Given this list of marker genes Tmem242, Nup107, Qtrt2, Atpsckmt (NCBI Gene Id 68073), Mrpl51, Slc25a39, Spg7, Zmpste24, Tmem120b, Mdh2, Tex2, Ndufb3, Eif5a, Cox18, Nipsnap1, Scrn1, Sec13, Mrps12, Sigmar1, Ndufb2, Lpin1, Mrps6, Thap7, P2rx6, Timm17a, Ndufs6b, Creb3l4, Mrps35, Parp16, Adap2, Etfdh, Mtg1 (NCBI Gene Id 212508), Vps4a, Gatm (NCBI Gene Id 98899), Coq6, Mrpl4, Mrpl15, Pmpca, Mtx2, Zfp354c, Bnip1, Arl2, Mrpl2, Mrps11, Tmem14a, Slc8b1, Cyp1a1, Foxo3, Tmem109, Lmna, Slc22a3, Cept1, Ipo9 (NCBI Gene Id 98447), Aurkaip1, Rae1, Mindy3, Chmp1a, Znfx1, Ntrk3, Fam169a, Slc25a11, Nup93 (NCBI Gene Id 71805), Tomm70a, Atp5f1d, Calm1, Nudt9, Mlx, Slc25a51, Calr3, Ptcd3, Kcnk9, Tmx2, Ndufb6, Sco2, Osbpl3, Bax, Atp5mg, Tmem223, Uqcrc1, Ints1, Rsad2, Rnf5, Gmcl1, Acat1, Rab5if, Coq10b, Dnajb14, Pgrmc2, Uqcrb, Arl6ip6 (NCBI Gene Id 80483), Rab32, Bak1, Rbm15b, Slc41a3, Syne2, Armcx1, Slc29a3, Slc44a2, Ugt2b38, Qrich2, mt-Co3, Rb1cc1, Suox (sulfite oxidase), Bcl2l1, 2210016L21Rik, Spart, Bad, Ndufv3, Fahd1, Alox5ap (NCBI Gene Id 11690), Dap3, Ckmt1, Ccnd2, Nup88, Gstk1, Cep128, Traf3ip3, Nup58, Slc25a42, Tyro3, Slc25a37, Ptgs2 (prostaglandin-endoperoxide synthase 2), Cidea, Slc25a26, Noc4l, Trim27, Trap1, Alox5, Ndufa13, Ran, Mtarc2, Cyp27b1, Pcm1, Gabbr1, Grk2, Pdss1, Mrpl27, Idh2, Misfa, Atp5mc1 (NCBI Gene Id 11951), Efhd1, Snca, Chchd3, Pemt, Syne1, Ghdc, Cask, Higd2a, Slc25a1, Oit3 (NCBI Gene Id 18302), Cox7a2, Atr, Syne4, Bcl2a1a, Haao, Mt3, Agtr1a, Cyp11b2, Foxred1 (FAD-dependent oxidoreductase domain containing 1), Sdhc, Coq5, Rcc1l, Mrps18c, Nup50, Parp8, Mavs, Gpx4, Cyb5r3, Rbmx2, Cps1, Hsd3b8, Spast, Ndufa12, Ptger3, Slc29a2, Cacybp, Smad3, Mcu, Slc25a21, Cyp2b10, Nrp1, Bcl2a1c, Tomm34, Mrpl44, Slc25a24, Dhrs1, Chchd4, Dnase1, Inpp4a, Mcub, Slc44a1, Slc25a33, Bdh1, Ndufa9 (NADH:ubiquinone oxidoreductase subunit A9), Chmp4b, Sdhaf3, Atp5pd, Nrgn, Nav3, Crat, Pebp1, Sorl1, Smim20, Nme6, Narf, S2bpcox16, Coq3, Nup50l, Bckdhb, Apool, Ppp1r15a, Nlrp6 (NLR family, pyrin domain containing 6), Mapk8ip1, Tnmd, Hadha, Mapk3, Gcdh, Ndufb9, Ggn, Maoa, Mrps34, Calr, Acsl3, Pam16 (NCBI Gene Id 66449), Vdac3, Nup42, Tmco1, Mrpl38, Mtmr6, Qtrt1, Fndc1, Apc, Dpy19l2, Dnajb12, Agpat5, Cox8c, Kpna2rt, Rars2, Prnp, Romo1, Mrps14, Cpt1a, Dync1h1, Slc25a27, Nme2 (NCBI Gene Id 18103), Mx1, P2rx7, Mgarp, Habp4, Tmem97, Nrxn1, Lmnb1, Lrrk2, Plpp7, Osbpl7, Hadhb, Ddx19b, Dnajc1, Cox6b1, Lemd3 (LEM domain containing 3), Slc25a3, Slc30a2, Apoo, Ppp1cc, Hsd11b1, Sord, Acacb, Ubb, Coq2, Mrps33, Gadd45gip1, Mrpl33, Eno1b, Ranbp1, Ryr2, Cox14, Miga1, Ndufb4, Nsmf, Parp6 (poly (ADP-ribose) polymerase family, member 6), Bbc3, Atp5mf, Fam162a, Slc25a40, Atad3a, Clip1, Cox16, Cox7a1, Stoml2, Tmem70, Cox11, Sun5, Cnp, Hpn, Xpo1, Rab40b, Plaat1, Stard13, Ptpmt1, Mff, Grpel1, Oma1, Pml, Des, Exd2, Slc22a4, Zc3hc1, Rangap1, Ednrb, Muc20, Tamalin, Nxf2, Mrpl53, Repin1 (replication initiator 1), Ptger4, Slc39a9, Hsd3b1, Tk2, Micos10, Mrpl9, Apeh, 4930550C14Rik, Ern1, Gsdma3, Mrps28, Ubc, Tor3a, Slc25a45, Pum2, Hkdc1, Plcd1, Itgb4, Erbin, Map1lc3b, Trpc7, Mrpl22, Afg3l2, Calm3, Ogt, Ifi27l2a, Slc8a3, Slc25a5, Itprip, Msto1, Bnip3l-ps, Rrm1, Adra1b (NCBI Gene Id 11548), Slc27a3, Bnip3l, Abcd3, Fzd9, Mgst3, Micu1, Mtx3, Rgs7, Spata46, Scai, Dao, Cptp, Prickle2, Tst, Sfxn1, Ltc4s, Lmo7, Lyrm7, Mrs2, Atp5f1c (ATP synthase F1 subunit gamma), mt-Nd4, Mrpl36, Sun3, Ndufa11, Pom121l2, Ldhd, Agk, Cenpv, Stx17, Hax1, Tnpo3, Ptrh2, Cyb5b, Smim30, Abcd1, Pptc7, Flvcr1, Ugt2b5, Nup155, Acad9, Srgap2 (SLIT-ROBO Rho GTPase activating protein 2, NCBI Gene Id 98351), Cmtm3, Ckmt2 (NCBI Gene Id 76722, creatine kinase, mitochondrial 2), Slc25a25, Tmem209, Nup210l, Got2, Myoc, Tmem33, Acads, Itpr3, Mrpl46 (mitochondrial ribosomal protein L46), Pigbos1, Ttc12, Rab7, Vdac2, Vrk2, Nutf2-ps1, Parp1, Dync2i2, Kpnb1, Timm8b, Uqcrq, Mns1, Nup43, Tomm20, Marchf5, Nat8f1, Nup62, Tmem256, Stx1a, Acsl5, Ndufa8, Ndufa1, Sphk2, Nutf2, Cfl1, Miga2, Gsdmd, Micu2, Anxa11, Dhrs2 (NCBI Gene Id 71412), Cabs1, Rtn4ip1, Phf11, Pnpla8, Tmem126b, Vdac1, Pet100, Tspo2, Endog, Smpd5, Cox17, Mrps15 (mitochondrial ribosomal protein S15), Mrpl21, Clpb, Dnajc15, Becn1, Ndufa10, Tomm22, Nup62cl, Eny2, Ahctf1, Sdcbp, Spire1, Lypla1, Timm21, Gle1, Yme1l1, Fam209, Aldh3a2, Mix23, Nucb2, Cox7a2l, Ccdc51, Ociad2, Golt1a, Xpot, Chmp4c, Bcl2l10, Mrps22, Cox20, Gfer, Tubb5, Micos13, Mrpl55 (mitochondrial ribosomal protein L55), Bltp1, Acsl4, Tufm, Wdr3, Sort1, Cybb, Letm2, Nnt, Ggnbp1, Brip1 (NCBI Gene Id 73108), Cox8a, Nlrp10, Acadm, Eno1, Armcx2, Shmt2, Iigp1, Wtap, Phf11b, Mpc2, Tor2a, Mrpl19, Mrps17, Lmnb2, Sco1, Cycs, Mrpl35, Pcx, Cse1l, Mul1, Mrps26, Slc25a19, Cstad, Gtpbp4, Aaas, Armc12, Fis1, Ndufab1-ps, Fgr, Rnf185 (ring finger protein 185), Fam3b, Slc25a38, Ghrhr (NCBI Gene Id 14602), Mrps21, Nudt1 (nudix hydrolase 1), Tmem160, Sirt5, Atp5pb, AU015836, Card19, Apoe, Otulinl, Atp1b4, Rbm15, Pla2g4b, Acaa2, Mta1, Slc25a43, Ctnnb1, Vcf2, Chmp2b, Coq7, Ackr2, Ifi27l2b (interferon, alpha-inducible protein 27 like 2B), Noa1, Tamm41, Mfsd10, Tmem126a, Smad1, Rnf6, Snn, Cyp11b1, Fkbp10 (FK506 binding protein 10), Mtor, Prelid1, Dctn1, Ndufa6, Banf1, Prodh2, Zftraf1, Smpd4, Ndufs4, Nos1ap, Sun2, Atpaf1, Nat8l, Nup54, Prelid3b (NCBI Gene Id 98755), Tigar, Slc25a20, Atraid, Ndufc1, Rdh13, Rmdn3, Degs1, Uqcrc2 (NCBI Gene Id 67003), Prr14, Ugt2b1 (UDP glucuronosyltransferase 2 family, polypeptide B1), Mfn1, Slc25a47, Fkbp8, Terb2, Cox4i2, mt-Nd3, Pla2g4a, Pnpt1, Clmn, Ndufa4, Ndufaf3, Bnip3, Aen, Acsl1, Cyc1, Ednra, Guf1, mt-Cytb, Smdt1, Nup188, Coq4, Rnf123, Htra2, Ipo8, Prkn, Ndufc2, Coq9, Syne3, Plaat3, Cox19, Slc25a16, Ndufv2, mt-Co2, Mrps5, Sdhd, Herc2, Gja1, Timm23, Cenpf, Nat8f7, Phf11d, Il15ra, Abcb8, Grk5, Cnr1, Clpx, Phf8, Ngfr, Sfxn4, Ogdh (NCBI Gene Id 75674), Mrpl49, Lgals3, Mrpl18, Abhd6, mt-Nd6, Slc25a35, Ist1, Bri3bp, Clca2, Star, Slc1a3, Irag2, Gabrb1 (NCBI Gene Id 320243), Atp5mj, Clu, Timm22, mt-Nd2, Cibar1, Surf4, Mrpl47, Ugt2b37, Tmem14c, Pom121, Vapa, Slc25a13, Crls1, Rab11fip5, Antkmt, Dnajc30, Ndufs3, Plekhn1, Ndufb8, Uqcr11, Dhx37, Spag4, Gpam, Hmgcl, Hsd3b4, Mrpl23, Sumo1, Kash5, Mtch2, Prodh, Vps13a, Tomm5, E2f5, Chchd2, Lmntd1, Klk6, Sdhb, Nup214, Alas1, Ndufab1, Pola1, Cebpzos, Abca12, Ugt1a6a, Spata18, Cyp2e1, Chmp5, Mtnap1, Ranbp17, Pmpcb, Mrpl16, Hlcs, Maip1, Nup153, Tmc8, Cyp11a1, Rhot1, Nelfb, Ndufaf6, Atp5me, Prkca, Mrpl58, Mrps10, Ei24, Ipo11, Uqcc3, Ndufb5, Armcx6, Uaca, Stat3, Aifm2 (NCBI Gene Id 78860), Klhdc2, Arg1, Trak1, Plrg1 (NCBI Gene Id 99527), Coa4, Epha3, Nme3, Hacd3, Eci1 (enoyl-Coenzyme A delta isomerase 1), Coq8a, Pink1, Akr7a5, Adra1a, Dele1, Ass1, Ppox, Ucp1, Cyct, Mad2l1, Ube2i (NCBI Gene Id 76085), Glud1, Atp5f1a, Tmpo, Pafah1b1, Smcp, Gk2, Parp11, Myct1, Kcnj11, Ldhb, Mrpl42, Mpc1, Tor4a, Slc25a44, Gcat, Timm8a1, Cep131, Mrgprf, Dnajb2, Plec, Cox7c, Mcm3ap, Htatip2, Rrp12, Mrps7 (mitchondrial ribosomal protein S7), Akap1, Insr, Tmem186, mt-Atp8, Abca8b, Mx2, Chil3, Mtfr1l, Mtch1, Slc25a22, Rps3, Mrps27, Slc25a15, Rap1gap2, Phf20, Ndel1, Cnep1r1, Nme1, Akirin1, Acsl6, Ndufa5, Rnf13, Tmem18, Tpr, Egfr, Slc25a14, Xpo4, Pdk4, Ppif, Akap6, Letmd1, Uqcc2, Myof, Slc25a12, Acad11, Tfdp2, Stmp1, Polr2m, Tspo, Pla2g2a, Yeats4, Ptpn1, Sh3bgrl2, Sephs1, Bcl2a1b, Slc25a32, Cox6b2, Mpv17, Atpaf2, Nemp2, mt-Nd5, Rnf144b, Bin1, Slc11a2, Prkcz, Bcs1l, Mcur1, Ebp, Dst, Dctn5 (dynactin 5), Kif28, Samm50, Rasa1, Canx, Wasf1, Chchd6, Slc25a29, Cmc4, Nxf1, Phf11a (NCBI Gene Id 71191), Ttc19, Mrpl3, Cox7b2 (NCBI Gene Id 78174), Cdk2, Chchd2-ps, Agpat4, Gch1, Polg, Ivd, Tmem38a, Fundc1 (NCBI Gene Id 72018), Nrm, Alas2, Gapdhrt, Gramd4, Lmntd2, Tent4a, Abcg2, Uqcrh-ps1, Dusp18, Mrpl34, Immp1l, Mtfp1, Ndufs6, Mrpl57, Sfxn5, Chmp6, Cbx3, Slc25a28, Majin, Slc25a30, Aifm1, Sirt4 (NCBI Gene Id 75387), Mrps18a (mitochondrial ribosomal protein S18A), Suv39h1, Mthfd2l, Cisd1, Cpne1, Mief1, Smim26, Mrpl52, Abcb7, Gata6, Cetn3 (centrin 3), Mrpl39, Cox7b, Tmem43, Spata19, Dhfr, Slc25a34, Dhodh, Mrpl20 (NCBI Gene Id 73950), Bik (NCBI Gene Id 12124), Tnks, Mad1l1 (NCBI Gene Id 17120), Timm13, Tomm7, Selenon (selenoprotein N), Cyp2u1, Nlrx1, Rif1, Phb2, Hsd17b8, Grpel2, Tmc6, Myo6, Akt1, Ngrn, Dnm1l (NCBI Gene Id 74006), Fxr1, Rhbdd1, Nr4a1, Terb1, Abcb10, Immp2l, Fdx1, Slc30a1, Eif6, Mrpl41, Park7, Slc27a1, Rexo2, App, Tmem168, Hsd3b3, Unc50, Nxt1, Coa3, Csde1, Tmem120a, Nup205, Emd, Acadvl, Mrps30, Nme4, Tmem11, Ndufs2, Cetn2, Pde2a, Oxa1l, Arl2bp, Nup85, Stau2, Irgm1, Pik3c2g, Nxt2, Ndufa7, Agpat3, Aqp8, Atf2, Ndufs5, Vps13c, Aqp1, Dmpk, Srsf1, Mrps31, Chchd5, Hccs, Ptgs1, Pank2, Mrps16, Dtl, Surf1, Cav2, Fbxw11, Pisd, Kcnh1, 1600014C10Rik, Anxa7, Ptges, Hsd3b6, Slc25a41, Tmx4, Nup133, Coq8b, Tyms, Cdh5, Epc1, Slc22a14, Vat1, Gper1, Fate1, Lrpprc, Smox, Eral1, Hsd3b9, Ndc1, Atp5mc2, Ndufa3, Lyn, Uqcc4, Tug1, Ubxn4 (NCBI Gene Id 67812), Apex2 (NCBI Gene Id 77622), Tbc1d20, Gapdh-ps15, Otc, Micu3, Atg9a, Chdh (NCBI Gene Id 63829), Cdc25c, Hk1, Tmem135, Fundc2b, Bcl2a1d, mt-Co1, Faf1, Chmp1b2, Chmp1b, Igf2r, Timm50, Atp5mk, Mlxip, Mtarc1, Bcl2, Aifm3, Slc16a3, Rnaset2a, Cd2ap, Ndufb10, Pla2g4c, Adck1, Rogdi, Nbr1, Mrpl43, Pgam5, Mrpl30, Ufl1, Tomm40, Pln, Bltp2, Sting1, Cox8b, Wdfy3, Tmem201, Sqor, Pdss2, Tor1aip1, Tnks2, Coasy, Dmac2l, Coa6, Reep1, Dnajc19, Capn10, Twnk, Fzr1, Immt, Afg1l, Ndufaf4, Stx1b (syntaxin 1B), Gsto1 (glutathione S-transferase omega 1), Tor1b, Slc25a36, Mrps25, Dusp2, Atp5f1b (ATP synthase F1 subunit beta), Mrpl28, Tmem147, Hadh, Uqcr10, Ints2, Cyp27a1, Dnajc2, Disp3, Chchd1, Atp5pf, Mrps23, Ints5, Chchd10, Mrps24, Gnaq, Ndufaf5, Phf11c, Cdk4, Ankrd17, Bicd2, Slc22a18, Slc30a9, Higd1a, Shisa5, Suclg1, Acadl, Atp5mc3, Cpt1b, Mrps18b, Neu4, mt-Nd1, Taf3, Slc25a48, Kif5b, Kpna4, Sod2, Exog (NCBI Gene Id 208194), Atad1, Cisd2, Uqcrfs1, Timm8a2, Ctdnep1, Plscr3, Slc25a10, Timm44, Tmem65 (transmembrane protein 65), Prelid2, Ccnd1, Cep89, Mad2l1bp, Ranbp2, Elk1, Ndufs8, Prickle1, Ptgds, Myo19, Pak5, Ndufb4b, Timm9, Sdha, Slc25a23, Pcna, Phb1, mt-Atp6, Moap1, Tra2b, Osbpl8, Dars2, Armc10, Calm2, Zfp383, Slc25a46, Ambp, Tomm20l, Itpr1, Epha4, Snph (syntaphilin), Sult1e1, Cemip, Mrpl45, Ccs, Uqcc5, Rnf180, Nell1, Mrpl10, Dnajc11, Cst3, Ndufb1, Prelid3a, Utp18, Trabd, Cd38, Vps4b, Nup98, Nos1, Ikbke, Senp2, Ccar1, Sh3glb1, Mcl1 (myeloid cell leukemia sequence 1), Zbtb1, Timm17b, Trmt10b, Plpp6, Hsd17b10, Mrpl54 (NCBI Gene Id 66047), Ndufs7 (NCBI Gene Id 75406), Itsn1, Tnrc18, Cox15, Cox6c, Cox5a, Lbr, Bcl2l13, Bche, Slc25a18, Mgst2, Armc1, Mccc1, Trappc2b (trafficking protein particle complex 2B), Triap1, Gapdhrt2, Mrpl48, Psen2 (NCBI Gene Id 98295), Chmp7, Opa1, Lrrc59, Gchfr, Phlpp1, Gk, Maco1, Armcx3, Cpt2, Casc3, Sts, Hsd3b5, Nup35, Fundc2, Fdxr, Osbpl6, Tomm40l, Psen1, Kmo, Tor1a, Rnaset2b, Gapdh, Pi4kb, Uqcc6, Mapkap1, Ifi27, Npc1 (NCBI Gene Id 98121), Asl, Mrpl24, Ak2, Rtcb, Fam210b, Ghitm, Golph3, Usp30, Slmap, Cox10, Chmp3, Tomm6, Dusp21, Ndufb11, mt-Nd4l, Dhcr7, Mrpl14, Slc3a1, Ndufb7, Ipo7, Parl, C9orf72, Slc25a31, Nup210, Nemp1, Timm10, Nln, Cox4i1, Seh1l (NCBI Gene Id 72124), Ndufs1, Sirt1, Serac1, Gtf3c3, Pak1, Chmp2a, Zdhhc8, Rac2, Ccdc90b, Brap, S100a6 (NCBI Gene Id 20200), Sun1, Gdap1, Coa7 (cytochrome c oxidase assembly factor 7), Cox6a2, Ipo5, Atp5f1e (ATP synthase F1 subunit epsilon), Timmdc1, Mlip, Pcid2, Spdya, Anxa1, Abcf1, Mrpl13, Bid (NCBI Gene Id 72579), Cox5b, Mtdh, Flvcr2, Thop1, Sfxn2, Mrpl50, Tafazzin, Atxn3, Mpl, Uqcc1 (ubiquinol-cytochrome c reductase complex assembly factor 1), Atcay, Sirt3, Kpna2, Mpv17l2, Fpgs, Nradd, Scgb1a1, Synj2bp (synaptojanin 2 binding protein), Napepld, Timm10b, Them4, Elavl4, Sod1, Trim14, Rtel1, Src, Sarm1, Bloc1s1, Ache, Gpd2, Tmem170, Xpo7, Ndufa2, Rtn4, Txlng, Ak9, Bok (NCBI Gene Id 98569), Hoxa7, Fancl, Diablo, Sfxn3, Iffo1, Clic1, Cox6a1, Tmem177, Cpox, Brox (NCBI Gene Id 71678), Cuedc2, Myorg, Tmem53, Mrpl17, Gimap3, Cox6c2, Mrps9, Mrpl11, Gpat2, Dtx2, Mrps2, Chchd7, Ndufb4c, Tmem176b, Mrpl40, Ucp2, Ppp2r2b, Mrpl12, Senp1, Mtx1, Mfn2, Prkg2, Dmd, Bcl2l2, Hspd1, Bnip2, Mrpl32, Nup37, Rps6kb1, Atp5po, Alpl, Nup160, Fbxl4, Ndufv1, Mtg2, Anxa4, Sox10, Slc9b2, Abcb6, Spin1, Hk2, Nat8f3, Tm7sf2, Maob, Ciapin1, Tmbim6, Ndufb11b, Rnf43, Mgst1, Slc25a4, Uqcrh, Coa8, Timm29, Mrpl37, Aldh18a1, Lemd2, Ucp3, Mief2, Pld6, Mpst, Dmac1, Hsd3b2, Rhot2, Mtln, Rrm2, Afg3l1, Nipsnap2, Hmgcs2, Fech, Pgrmc1 (progesterone receptor membrane component 1), Plcb1, Pcyt1a, Retsat, Bdnf, Ubiad1, Ndufa11b, Tmx1, Mrpl1, Rnf220, Myzap, Letm1, here is a description of the gene set: Mouse Gene Set: GOCC_ORGANELLE_ENVELOPE A double membrane structure enclosing an organelle, including two lipid bilayers and the region between them. In some cases, an organelle envelope may have more than two membranes. studied in species Mus musculus